Given this list of marker genes MOGAT2, GPAM, LPIN3, LPIN2, MOGAT3, DGAT1, GK (glycerol kinase), GPAT2, GK2, LPIN1, MOGAT1, DGAT2, AGMO, GK3, here is a description of the gene set: The overall process of triglyceride (triacylglycerol) biosynthesis consists of four biochemical pathways: fatty acyl-CoA biosynthesis, conversion of fatty acyl-CoA to phosphatidic acid, conversion of phosphatidic acid to diacylglycerol, and conversion of diacylglycerol to triacylglycerol. Reactome Pathway: Triglyceride biosynthesis studied in species Homo sapiens part of: Triglyceride metabolism